Given this list of marker genes ANKDD1B, TAF15, LIX1 (limb and CNS expressed 1), CCNL2, MATN4, ITFG2, BNIPL, RAPGEF5, NUP210, ZNF600, ABRAXAS2, KATNB1, NCKAP5, ZFP36L2, SNX7 (sorting nexin 7), NCK1, GLRA2, TAF6, RAD51AP1, SPATA6L, AVIL, PTPRG, PNRC1, CECR2, SNRNP200, SLC37A1, CDH11, ULBP1, VPS26B, TMEM132C, UTRN, SMYD5, ITGB4, CD163, MKRN2, EIF2AK3, THAP2 (THAP domain containing 2), MAEL, RUVBL2, C17orf75, SOX1, IQSEC2, ARHGEF38, AMOTL1, EML4, FBXW5 (F-box and WD repeat domain containing 5), PYGB (NCBI Gene Id 5834), POFUT1 (NCBI Gene Id 23509), DZANK1, ILK, DHX35, PDE3A, DAZ2, LIN7A, DARS2, CD36, TCF25, N4BP1, SATL1, NF2, FBXO46, BMP10, BRMS1L, NUSAP1 (NCBI Gene Id 82534), FAM110C, CPEB3, ZDHHC15, AIP, NEK4, POLA1, TBC1D10B, ZNF598, B3GALT2, JAK3, CLK2, ABHD10, UNC5A, MROH1, NPHP3, ARFGEF1, SGPP2, DENND4B, CHID1, MTMR3, ERC1, DNAAF9, ZC3H6, TRAF7, PRAMEF8, FHIP2A, APOBEC4, RNF214, COPG1, PHF20L1, CATSPERZ, UACA, NR4A1, LDLRAD4, PHLPP2, PRDM4, AGO1, DENND2D (DENN domain containing 2D), ST7, HECA, ADNP2, ZIC3, MAML1, TSPAN14, PCED1A, MAPK8IP3, FBXW7, USP30, ADAM28, ATG16L1, ELOVL4, PCDHB2, FAM110A, HTR3B, FAM81B, FOXB1 (NCBI Gene Id 27023), FCHO1, MR1, IRF2, NAIF1, ANKRD35, TMEM8B, PROK2, KRT12, VNN1, MRI1, HSD17B3, PTK6, ZMAT1, PLEKHA6, STOX1, EEFSEC, PLPP6, SLC9A5, SYCP1, FBXL3, RFXANK, ABTB1, MPV17L2, AHCYL1, MNT, AHSG, BPIFB2, OPALIN, LANCL2, MRC2, FAM89B, RNF41, RNF123, ZNF516, MIIP, TEX36, HROB (homologous recombination factor with OB-fold), FAM193A, ZFP36L1, USP9X, NISCH, MATN2, LRRC41, SLC2A8, CNTN6, SMAD6, UBE2B, ODF4, SLMAP, ZNF688, RAB22A, RASAL3, EXOC3L1, PLEC, CTSK, ZFHX3, CFAP20, TOR1AIP1, ARSK, GJC3, LONRF2, IL22RA2, KBTBD2, RAPH1, CRYGS, PCDH20, SACS, PLEKHG5, H1-10, SSH3, GRIA1, ATF6, WDR62, PARPBP, PDK4, EFEMP1, SPG7 (NCBI Gene Id 87549), C4orf46, TDP2, CPA3, here is a description of the gene set: Human Gene Set: GSE4142_PLASMA_CELL_VS_GC_BCELL_UP from publication Luckey CJ, Bhattacharya D, Goldrath AW, Weissman IL, Benoist C, Mathis D (PMID 16492737) species: Homo sapiens In order to better understand the factors that regulate B cell differentiation upon exposure to antigen, we compares global gene expression profiles from naive B cells with antigen-specific plasma, germinal center, and memory B cells after immunization with the T-dependent antigen, NP-CGG. The memory B cell-enriched transcripts were then compared with memory T cell-enriched and hematopoietic stem cell-enriched transcripts in order to generate a transcriptional profile of self-renewal within the hematopoietic system. Genes up-regulated in plasma cells versus germinal center B lymphocytes.